The following is a description of a gene set: Any process that increases the rate, frequency or extent of nitric oxide mediated signal transduction. Nitric oxide mediated signal transduction is The series of molecular signals mediated by the detection of nitric oxide (NO). studied in species Mus musculus Mouse Gene Set: GOBP_POSITIVE_REGULATION_OF_NITRIC_OXIDE_MEDIATED_SIGNAL_TRANSDUCTION, and this is the list of marker genes: Ins1, Gucy1a1, Kdr, Gucy1a2, Ins2